Given this list of marker genes Urod, Ppox, Hmbs, Cpox, Alad, Uros, Alas1, Fech, here is a description of the gene set: Mouse Gene Set: GOBP_HEME_B_METABOLIC_PROCESS The chemical reactions and pathways involving heme b, a Fe(II) porphyrin complex readily isolated from the hemoglobin of beef blood, but also found in other proteins including other hemoglobins, myoglobins, cytochromes P-450, catalases, peroxidases as well as b type cytochromes. species: Mus musculus